The following is a description of a gene set: We demonstrated recently that both constitutive and FAS-triggered apoptosis of human neutrophils are profoundly impaired by Francisella tularensis, but how this is achieved is largely unknown. To test the hypothesis that changes in neutrophil gene expression contribute to this phenotype, we used human oligonucleotide microarrays to identify differentially regulated genes in cells infected with F. tularensis strain LVS compared with uninfected controls. In order to examine the effect of F. tularensis on the neutrophil transcriptome, we performed microarray expression analysis on human neutrophils treated with F. tularensis subsp. holarctica live vaccine strain (LVS). studied in species Homo sapiens from publication Schwartz JT, Bandyopadhyay S, Kobayashi SD, McCracken J, Whitney AR, Deleo FR, Allen LA (PMID 22986450) Genes up-regulated in comparison of control polymorphonuclear leukocytes (PMN) at 48 h versus PMN treated with F. tularensis vaccine at 48 h. Human Gene Set: GSE37416_CTRL_VS_48H_F_TULARENSIS_LVS_NEUTROPHIL_UP, and this is the list of marker genes: MISP, GAMT, TFAP2A, CEACAM8, GJB4, VAMP8, VIPR2, FNDC4 (NCBI Gene Id 64838), TMEM223, CLUHP3, DNAJC15 (NCBI Gene Id 29103), KLHDC1, TCTN3, HSPA1A, HS3ST5, GCFC2, RRM1, DPH5, AKAP7, RNGTT, KBTBD7, TCF7, LGALS9, CFAP157, XAF1, SMC2, RDX, NUP210 (NCBI Gene Id 79985), GPAM, KPNA5, SERTAD4, OAS1, CSTF3 (cleavage stimulation factor subunit 3), ENKUR, SPDEF, RNF125, CACNG4, CLRN1 (NCBI Gene Id 7401), RSAD2, LINC00957, APOL6, LARP4, AQP4-AS1, OASL, MAP4K1, SATB2, SLAMF6, GFOD3P, BUB1B, GIMAP4, RHEX, TTC29, NOD1 (NCBI Gene Id 10392), ADAMTS10 (ADAM metallopeptidase with thrombospondin type 1 motif 10), SLA2, ACAT1 (acetyl-CoA acetyltransferase 1), TRAC, RARG, SAMD9, MVK, ZNF579, GSTCD, RLIG1, ANAPC15, UBL4B, EMB, OR7E104P, C10orf67, SLC38A6, CNDP1, KIFAP3, GAS6, CACNA1G-AS1, CX3CR1, TRAT1, IFNA14, SNTG1 (NCBI Gene Id 54212), DEPDC1, LRFN5, MS4A4A, GOLGA8H, LAMC1, MKX, ERICH5, ASB13, FUT3, ESS2, SNX7, GRIN1, MPRIP, HERC5, TRIM22, APOBEC3G, FCMR, EVI5L, BOLA3, DUT, IFNLR1, PRIMPOL, OAS2, RCAN3, NLGN1, EPHA5 (EPH receptor A5), VRK2, CCDC157, WT1, SHE, TMEM176A, DNAJB5, MMP12, PSMD14, CYBRD1, ARMC1, ZC3HAV1, FANCI, ZNF548, LCN2, ITGA4, CLC, BIN2, FAM169A, ABCD3, TCF4, SP110, GRIA2, BCL11B, GIMAP2, E2F2, IFIT3, GFOD1, CTSE, ABHD10, OR51B2, IKZF2, NSUN5P1, CDH22, FAM218A, AGK, S1PR4, PCGF6, TRIM44, SH2D1B, TEX55, PAPPA, ARHGEF6, ACACB, SEMA4F, COL9A2, BAZ1B, TFAP2E, C19orf84, CLCF1, CHEK2, MDFIC (MyoD family inhibitor domain containing), SULT1B1, ZNF93, FGF7P3, SHISA2, SHLD2, CDIN1, DHFR, MTFR1, ZWILCH, PTDSS1, LINC02762, TCN1, RACGAP1, RABEP2, RALGPS1, ATP9A, CCKAR, CD3G, ABHD15, OAS3, DDX60, SORBS1, GATA1, DAND5, WDR3, STMN3, MPZL1, ATP1B1, SAMD9L, ENSG00000237870, GGCT, ATP5F1A, RUFY3 (RUN and FYVE domain containing 3), RIOX1, ELAPOR2, RFLNB, TBC1D1, CAMP (cathelicidin antimicrobial peptide), B3GNT4